The following is a description of a gene set: Human Gene Set: HP_ABNORMAL_MAGNESIUM_CONCENTRATION Abnormal magnesium concentration An abnormality of magnesium ion homeostasis. studied in species Homo sapiens, and this is the list of marker genes: SARS2, CLCNKA, KCNJ1, RRAGD, CLCNKB, CTNS, GNB2, DBH, KCNJ18, SLC12A1 (solute carrier family 12 member 1), PLVAP, EGF, GCM2, FOXP3, BSND, CASR, AP2S1, CLDN16, TRPM6, TBCE, ALDOB, TIAM1, SLC12A3, CLDN19, GABRA3, CNNM2, CACNA1S (calcium voltage-gated channel subunit alpha1 S), POLRMT, ATP1A1, CLDN10 (NCBI Gene Id 9071), GNA11, PCBD1, FXYD2, KCNJ10 (potassium inwardly rectifying channel subfamily J member 10)